Given this list of marker genes DES, MT-TS2 (mitochondrially encoded tRNA-Ser (AGU/C) 2), MT-TF, ALPK3, NDUFS4, TNNC1, MT-TQ, MT-TH, MT-TL1, MT-CO1, TSFM, MT-ND1, MT-CO3, MT-ND6, MT-ND4, MT-TW, MT-ND5, CLN3, FHOD3, MT-CO2, here is a description of the gene set: species: Homo sapiens Human Gene Set: HP_CONCENTRIC_HYPERTROPHIC_CARDIOMYOPATHY Concentric hypertrophic cardiomyopathy Hypertrophic cardiomyopathy with an symmetrical and concentric pattern of hypertrophy.